The following is a description of a gene set: Folate-alcohol and cancer pathway hypotheses studied in species Homo sapiens Human Gene Set: WP_FOLATEALCOHOL_AND_CANCER_PATHWAY_HYPOTHESES, and this is the list of marker genes: MTHFR, MTR, ALDH1A1 (NCBI Gene Id 96075), CREB1, ALDH1L1, CYP2E1, ADH5, CEBPB, CBS